Given this list of marker genes GCHFR (NCBI Gene Id 2644), COQ8B, COQ6, NOS3 (NCBI Gene Id 4846), COQ7, AKT1, DHFR, PDSS2, COQ5, COQ3, HPDL, CALM1, IDH1, COQ4, STARD7, ACO1, PDSS1, GCH1, PTS, HSP90AA1, PRKG2, COQ9, SPR, COQ2, COQ8A, here is a description of the gene set: part of: Metabolism of vitamins and cofactors species: Homo sapiens Many proteins depend for their activity on cofactors, associated ions and small molecules. This module contains annotations of processes involved in the synthesis of cofactors, either de novo or from essential molecules consumed in the diet (vitamins), as well as regeneration of active forms of cofactors. Reactome Pathway: Metabolism of cofactors